Given this list of marker genes PDGFRB, VAV1, HRAS, RAC1, MAP2K1 (NCBI Gene Id 5604), MAP2K4, MAPK3 (mitogen-activated protein kinase 3), NFKB1, VAV2, STAT1, PDGFB, RAF1, CDC42, RHOA, NFKBIA, CHUK, MAPK8, TIAM1, SRF, MAP3K1, SHC1, JUN, FOS, RASA1, PAK1, JAK1, SOS1, PLA2G4A, MAPK1, GRB2, PLCG1, PIK3R1 (NCBI Gene Id 5295), ARFIP2, SRC, ELK1, PDGFA, PTPN11, WASL, MT-CO2, STAT3 (NCBI Gene Id 6774), here is a description of the gene set: PDGF pathway species: Homo sapiens Human Gene Set: WP_PDGF_PATHWAY